The following is a description of a gene set: Mouse Gene Set: GOMF_ALPHA_GLUCOSIDASE_ACTIVITY studied in species Mus musculus Catalysis of the hydrolysis of terminal, non-reducing alpha-linked alpha-D-glucose residue with release of alpha-D-glucose., and this is the list of marker genes: Agl, Gaa, Sis, Mogs, Ganab, Mgam2-ps, Mgam, Ganc